Given this list of marker genes TMOD1, SLC35A5, KIF2A, MTAP, PRKCQ, PSMB7, IARS1, TMEM268, STX17, SLC2A8, GPR107, DOCK8, RXRA, TGFBR1, FAM120AOS, CAMSAP1, FKTN, ABL1 (ABL proto-oncogene 1, non-receptor tyrosine kinase), RAD23B, EPRS1, SLC35D2 (solute carrier family 35 member D2), ENDOG, TRIM52, DAB2IP, MIS12, MSANTD3, NMRK1, SPTLC1, ZNF79, ZBTB34 (NCBI Gene Id 403341), PTGR1, TDRP, TOR1A, SLC9B2, PNPO, TRIM32, GNG10, ISCU, ECPAS, RBM18, XPA, NUDCD3, SMC5, RPL35, POLE3, ARPC5L, DDX3Y, VPS13A, SET, ANKH, ASS1, GRAMD1A, CORO2A, CDK5RAP2, PRPF4, ITPR2, SPOUT1, TOPORS, INIP, FUBP3, PSMD5, GOLGA1, RAB14, NEK6, TOR1B, DRC3, DUSP22, RABGAP1, LRRC8A, MFSD14B, CUL5, ASTN2, CREBL2, NUP214, GLE1, CDK9, PABIR1, SECISBP2, RARA, ATP6V1G1, KDM5D, PSMA2, ERP44, FBP1, CYB5D2, TMEM245, TSC1, SETX, ALG2, MRPL50, RNF38, FOXM1, GNAQ, NANS, CNTRL (centriolin), ABITRAM, SEC16A, DPP7, C9orf78 (chromosome 9 open reading frame 78), CARNMT1, ISCA1, APTX, KLHL9, PPP6C, TNFRSF10C, NUP188, SMARCA2, ANK2, ACO1, ANP32B, PTPDC1 (protein tyrosine phosphatase domain containing 1), FBXW2, UGCG, IPPK, PTPN3, SEC61B (NCBI Gene Id 10952), here is a description of the gene set: We used gene expression profiling, mutation analyses of FGFR3 and TP53, and LOH analyses of chromosome 9 and the TP53 region on chromosome arm 17p, to molecularly characterize 75 Ta and T1 bladder carcinomas. We identified four major cellular processes related to cell cycle, protein synthesis, immune response, and extra cellular components that contribute to the expressional heterogeneity of early-stage urothelial cell carcinoma (UCC). Activating FGFR3 mutations were found at the highest frequency in G1 tumors (80%), and showed a strong correlation with FGFR3 expression. In contrast, G3 tumors displayed mutations in less than 10% of the cases and a low level of FGFR3 expression. Even though LOH on chromosome 9 was not associated with any specific expression pattern, our data indicate that loss of chromosome 9 is associated with tumor development rather than initiation. The combined analyses suggest the existence of two types of UCC tumors, one which is characterized by FGFR3 mutation or expression, high expression of protein synthesis genes, and low expression of cell cycle genes. Furthermore, the presented data underscore FGFR3 receptor involvement in urothelial cell transformation as the presence of FGFR3 mutations has a major impact on the global gene expression profile of bladder carcinomas. Genes down-regulated in urothelial cell carcinoma (UCC) tumors with LOH on 9q as compared to the tumors showing retention. from publication Lindgren D, Liedberg F, Andersson A, Chebil G, Gudjonsson S, Borg A, Månsson W, Fioretos T, Höglund M (PMID 16532037) species: Homo sapiens Human Gene Set: LINDGREN_BLADDER_CANCER_WITH_LOH_IN_CHR9Q